Given this list of marker genes LPCAT1, FAM219A, ADNP, TMEM60, CLEC5A, AGO3, KIF13A, CAB39L, SEMA6B, MCTP1, FKBP15, DYNLL1, NDUFA10, NRIP1, CHMP2B, WLS, PNP, SPTLC2, SLC38A2, TMEM38B, FZD1 (NCBI Gene Id 8321), DAB2IP, PDCD6IP, TAOK3, NSF, ARFIP1, CBLC, MFAP3, SLC2A3, BCL2A1, LEPROT, EPHA10, SEC62, HK2, MGAM, TRIM13, SLAIN2, CTNND1, TRIB3, DAZAP2, TRIP12, LRRC8D, CAMTA1, USP9X, RAB2B, ERCC6L2, TGIF1, ZDHHC6, PPBP, TSG101, VWA8, SH3GLB1 (SH3 domain containing GRB2 like, endophilin B1), ACSL4, TRIM21, MED30, DCTD, NFAT5, TRPS1, TM6SF1, PCTP, IRAK1, PTPN12, BCAT1, RC3H2, TCF7L2, HSPBAP1, RNF144A, CARD6, KHNYN, TEX19, SWT1, ZNF626, MET, YRDC, LAPTM5, CNRIP1, EAF1 (NCBI Gene Id 85403), BTN3A1, LAMP2, CEBPB, BNIP3L, ICOS, VSIG2, SIRPB2, SPATA6, MFAP2, FBXL5, CCNQ, RHBDF1 (NCBI Gene Id 64733), KLHL23, TRIO, PRKCH, PINK1, NPC1, VCAN, FAM120AOS, ARHGEF3, SNX9, MYL12A, LINC00922, ACVR1B, STAU1, ANKZF1 (ankyrin repeat and zinc finger peptidyl tRNA hydrolase 1), BCL7B, PPIF, SERPINB8 (serpin family B member 8), LRRC2, STK24, FLT1, SCML1, IL24, GPR68, SPATS2, MAFG, PJA1, TSTD1, ATP8B4 (ATPase phospholipid transporting 8B4 (putative)), DUSP6, ALOX5AP, ADM, LINC02210, USP3, STX6, PID1, SMCHD1, PDK1, DDX60L, ST3GAL1, NAP1L3, EREG, WASL, ZC3H11A, RTN4RL2, TSC22D1, DIAPH1, SLC11A1, MAMLD1, SLC19A2, CREB3L2, CHIC2, SH3BP5, LAT2, CARD16, IP6K2, UGT2B28, MAPRE2 (NCBI Gene Id 51683), CCL7, LIMS1, NEDD4, CCL20, RIN3, CHMP5, KREMEN1, CARD8, EMP1, ASAH1, PNPLA8, LYSET, MED13, STX1A, KLHL15, PELO, TOR1AIP1, ARAP3, PHC2, TMPO, STAMBPL1, FAM47B, HTRA1, METTL9, BST1, YIPF6, BANP (NCBI Gene Id 54971), ATP9B, DAB2, PLAUR, CSNK1E, JAKMIP2, RUNX3, RALA (RAS like proto-oncogene A), ZBTB6, LTB4R, LGMN, YWHAZ, PTGS2, FHIP1B, THRB, EAF2, DCAF12, SPMIP4, VAV3, MTHFD2L, PPP6R3, SH3BGRL, FCAR, VCAM1, NXT2, ATP2B1, here is a description of the gene set: Effects of Neuromedin-U on gene expression in mouse D10.G4.1 T-cells natively expressing the GPCR Axor13 Human Gene Set: GSE1791_CTRL_VS_NEUROMEDINU_IN_T_CELL_LINE_6H_UP studied in species Homo sapiens Genes up-regulated in D10.G4.1 T cell line (6h): control versus treated with NMU. from publication Johnson EN, Appelbaum ER, Carpenter DC, Cox RF, Disa J, Foley JJ, Ghosh SK, Naselsky DP, Pullen MA, Sarau HM, Scheff SR, Steplewski KM, Zaks-Zilberman M, Aiyar N (PMID 15585845)